The following is a description of a gene set: studied in species Homo sapiens Human Gene Set: HP_ABNORMAL_BASAL_GANGLIA_MRI_SIGNAL_INTENSITY A deviation from normal signal on magnetic resonance imaging (MRI) of the basal ganglia. Abnormal basal ganglia MRI signal intensity, and this is the list of marker genes: MRPL39, SPG11 (SPG11 vesicle trafficking associated, spatacsin), ETHE1, MFF, SUCLG1, GCDH, ASL, PRNP, VPS11, MECR, MT-TK (NCBI Gene Id 4566), MT-ND2, LRPPRC, GTPBP3, PDE10A, MT-ND5 (mitochondrially encoded NADH:ubiquinone oxidoreductase core subunit 5), MT-TL1, MT-ATP6, ALG2, TACO1, COQ8A, MT-ND3, MICU1, MT-TV, ABCB7, GLI3, GFAP, MT-ND4, MT-TW, ASPA (aspartoacylase), NDUFS4, FASTKD2, SLC30A10, PDSS2, MT-ND1, NADK2, MT-ND6, SCO2, GLB1, NDUFS1